The following is a description of a gene set: Human Gene Set: MIR1185_5P species: Homo sapiens Genes predicted to be targets of miRBase v22 microRNA hsa-miR-1185-5p in miRDB v6.0 with MirTarget v4 prediction scores > 80 (high confidence targets). from publication Chen Y, Wang X (PMID 31504780), and this is the list of marker genes: DISC1, ALDH3B1, TSPYL1, SLC46A3, SGCD, ZNF117, MIS18BP1, VNN1, PEX12, BRWD3, SULT2A1, NPL, DMXL1, TRPA1, TDP1, MACC1, BAZ2B, GTF2H1, ABCA9 (NCBI Gene Id 10350), RABL3, MAOB, COPS3, KDSR, ICE2, ATP10D, AHR, KIAA0408, TMEM33, TEAD1, AFG2A, MED23, CD2AP, FGF13, ODAPH, IFITM2, ADGRL1, DHRS2, HINFP, SYTL2, MMRN1, OGFRL1, BCAM, PRELID2, CNTLN, CGREF1, NCMAP, NAIP, PDHB, IFITM3, CDC42SE1, PITPNB, SOS2, CRCP, KRIT1, AHNAK, RFT1, ITGA1, ZNF280D, RGS6 (regulator of G protein signaling 6)